Given this list of marker genes RAD23A, CEBPB, POLR2E, BRF1, MUC2, PRL, BAIAP2, GPR32, ARTN, ATP1A3, TAC1, TMBIM6, SRP14, ALAD, PFN1, FTL, KCNH2, HADH, APC2, COL9A1 (collagen type IX alpha 1 chain), ADAMTS4, INSL3 (insulin like 3), BECN1, LMX1B, PCBD1, SGCA, FTH1, ITGA3 (integrin subunit alpha 3), RGR, PFKFB2, MAD1L1, ZBTB17, GRN, IER3, LAD1, HNF1A, KIF5A, WIPF1, IRAG2, GHSR, INSIG1, CRABP1, FYN, NRTN, CALB2, COX6A2, CD79A, FBN1, PFKM, BAIAP3, SORBS2, ATP4B (NCBI Gene Id 496), H2AX, GRB7, CKM, PAX8, NDUFC1, MDK, OMP, HAGH, LAMB3, HOXA4, SLC30A3, PPM1G, MYD88, GP1BB, IDS, IRS1, EZH2, GFAP, KRT17, MYOG, NKX2-2, NPAS1, ARPC2, CDK8, MGAT3, CDX4, PCOLCE, MAPK10, PBX2, UPF1, TRAF1, SHMT2, FKBP1A, EIF6, LOXL1, CRYBB1, BICD1, PMS2P11, DVL1, AKT2, GABRA6, HMGN2, ATP6V0C, B4GALT5, GPR25, DHX16, HCFC1, SPEG, CEACAM3, GAMT, ACTN1, VGF, CHRNG, SPRR2B, PCYT1A, CYP19A1, AQP8, SFPQ, ASMTL, ISLR, INPPL1, EPHX1, MSR1, IKBKG, PCDHGC3, MAT1A (methionine adenosyltransferase 1A), BLK, CD151, CHRM4, RAD9A, CHRNB3, MYOD1, FOXJ1, SEPTIN5, CST5, ALOX15B, ADRA1B, KRT31, CA6, MYBPH (NCBI Gene Id 4608), PTPN3, PRM2, APLNR, SRY (NCBI Gene Id 6995), STX1B, GTF2F1, GABRA2, SHOX, ACTG2, NPBWR2, TLE3, DNASE1L2, TUBG1, ADAM15, MAP4K2, BMP7, ITIH1, STAM, GOLGA2, CD68, YWHAH, CTF1, MVD, TCF21, CRAT (NCBI Gene Id 1384), AMH, ADCYAP1, PAEP, here is a description of the gene set: Genes down-regulated in T98G cells (glioma, express MGMT) by carmustine at 48 h. studied in species Homo sapiens Chemotherapy with the alkylating agent BCNU (1,3-bis (2-chloroethyl)-1-nitrosourea) is the most commonly used chemotherapeutic agent for gliomas. However, the usefulness of this agent is limited because tumor cell resistance to BCNU is frequently found in clinical brain tumor therapy. The O6-methylguanine-DNA methyltransferase protein (MGMT) reverses alkylation at the O6 position of guanine and we have reported the role of MGMT in the response of brain tumors to alkylating agents. However, the different mechanisms underlying the patterns related to MGMT remain unclear. To better understand the molecular mechanism by which BCNU exerts its effect in glioma cell lines according MGMT expression, we used microarray technology to interrogate 3800 known genes and determine the gene expression profiles altered by BCNU treatment. Our results showed that treatment with BCNU alters the expression of a diverse group of genes in a time-dependent manner. A subset of gene changes was found common in both glioma cell lines and other subset is specific of each cell line. After 24 h of BCNU treatment, up-regulation of transcription factors involved in the nucleation of both RNA polymerase II and III transcription initiation complexes was reported. Interestingly, BCNU promoted the expression of actin-dependent regulators of chromatin. Similar effects were found with higher BCNU doses in MGMT+ cell line showing a similar mechanism that in MGMT-deficient cell with standard doses. Our data suggest that human glioma cell lines treated with BCNU, independently of MGMT expression, show changes in the expression of cell cycle and survival-related genes interfering the transcription mechanisms and the chromatin regulation. from publication Bandres E, Andion E, Escalada A, Honorato B, Catalan V, Cubedo E, Cordeu L, Garcia F, Zarate R, Zabalegui N, Garcia-Foncillas J (PMID 15980968) Human Gene Set: BANDRES_RESPONSE_TO_CARMUSTIN_MGMT_48HR_DN